Given this list of marker genes Abcc1, Atp1a2, Mme, Nf1, Pak1, Tbr1, Nr2e1 (nuclear receptor subfamily 2, group E, member 1), Uba6, here is a description of the gene set: The progression of the amygdala over time from its initial formation until its mature state. The amygdala is an almond-shaped set of neurons in the medial temporal lobe of the brain that play a key role in processing emotions such as fear and pleasure. Mouse Gene Set: GOBP_AMYGDALA_DEVELOPMENT studied in species Mus musculus